The following is a description of a gene set: studied in species Mus musculus IL-6 signaling pathway Mouse Gene Set: WP_IL6_SIGNALING_PATHWAY, and this is the list of marker genes: Mapk3, Bmx, Casp3, Ep300, Ppp2r2c, Hsp90aa1, Foxo1, Hdac1, Mapkapk2, Map3k7, Erbb2, Rb1 (NCBI Gene Id 19645), Ppp2r5b, Grb2, Cebpb (NCBI Gene Id 18031), Map2k6, Hck, Cd40, Hspb1, Eif4ebp1, Ppp2r2b, Bad, Jak1, Rps6kb1, Ppp2r3a, Il6ra, Fes, Sos1, Hras, Fgr (NCBI Gene Id 14191), Btk, Crebbp, Tyk2, Stat5a, Akt1, Lyn, Ppp2cb, Cdk5r1, Ptpa, Ppp2r5a, Eif2a, Ppp2r5e, Gsk3b, Pik3r1, Ppp2r2a, Jun, Inpp5d, Jak2, Vav1, Plcg1, Socs3, Foxo3, Stat1, Ppp2r1b, Mapk8, Cdk5, Map3k4, Raf1, Sgk1, Mapt, Hnf1a, Ppp2r5c, Pik3r2, Erbb3, Ppp2ca, Tec, Mapk1, Daxx, Pxn, Mapk14 (mitogen-activated protein kinase 14), Gab2, Ptpn11, Map2k1, Eif4e, Prkcd (protein kinase C, delta), Il6, Shc1, Ppp2r5d, Rac1, Ptk2, Ncoa1, Stat5b, Nlk, Rps6ka2, Il6st, Gab1, Foxo4, Casp9, Cdk9, Map2k2, Ptk2b, Map2k4, Fos, Ppp2r1a, Nfkb1, Stat3, Inppl1, Ar, Fyn